Given this list of marker genes PSME2, DENND2C, AGR2, BAALC-AS1, PSMB8, KCNE2, HTN1, FUT1, OPRPN, FLCN, GBP4, MAP3K20-AS1, SECTM1, SFXN2, SERPING1 (NCBI Gene Id 710), CRISPLD2, SLC2A12, TMCO5B, MYRFL, HCAR3, LAMA3, SYPL2 (synaptophysin like 2), WBP2NL, MMP25, UPB1, WARS1, FIZ1, THUMPD2, ANKRD22 (NCBI Gene Id 118932), RNF149, CALHM6, RHOC, APOL1, CREM, SLC25A31, APOL6, APOL4, MAP4K5, AK8, HLA-DRB1, ASZ1, SLC16A1, PLEKHA7, HRH4, INHBA, SPON1, SLC25A35, TXN, NLRC5, GEMIN2, SCLY, ZNF276, CARTPT, NDUFA10 (NCBI Gene Id 4705), STAT1, IGF2BP3, TRIM26, IL17D, TRIM69, CAMK2D, HORMAD1, ASCC3, GART, PARP14, HLA-A, KLLN, CT83, MAGEB2, HNRNPC, OPN5, CAPN12 (calpain 12), HSP90AB1, SAMHD1, ERAP2, GBP5, HLA-DPA1, OR4D1, TRPC5, CNGB3, FMO4, GBP1, RNF10, HLA-DMA, LYNX1, IRF4, MUC19, FSCB, B2M, LIG3 (DNA ligase 3), PLCB4, TRIM21, KLRD1, HOXC9, HLA-DRA, TLNRD1, ZFR2, PSMA3, TRAFD1, FSIP2, PSMB9, HELLS, GGTA1, LINC01278, MORC1, KDM2A, CEP41, TRIB2, CNTNAP5, BDNF-AS, RGS9BP (regulator of G protein signaling 9 binding protein), ENO1, PPP1R9A, MINAR1, PEG3, HLA-DRB6, CD2, TMEM229B, TMEM135, GDI2, SCAPER, PSMA2, MR1, DYNC1H1, STX5, FAM226B, TMEM39A, BTN3A1, PPP4R3A, SCGB1D2, ABT1, TMEM156, LINC01973, MRGPRX1, SPRR2B, OR2M4, IRF1, DCLK1 (doublecortin like kinase 1), DNPEP, HLA-DQB1, GIMAP2, PRPS2, PER3P1, NECTIN3, SIPA1L1, OR8D2, IL36RN, ENSG00000237250, UGT2B4, KIR3DL1, VPS9D1, KRTAP9-9, LINC00887, DNAJA1, HLA-B, RMDN3, NLRC3, GPR174, IL12RB1, SP140L (SP140 nuclear body protein like), ZNF236-DT, UBE2L6, TAP2, ADH1A (alcohol dehydrogenase 1A (class I), alpha polypeptide), POLB, FKBP2, GIMAP8, PDP1, ARHGEF28, CALCOCO2, KIR2DS3, TVP23A, LINC02223, LINC01142, GBP2, SSX1, E2F7, AP3M2, HLA-DPB1, CKAP2, SLC25A20, TOX2, PLAAT4, PLEKHO1, IQCH, STARD8, RAB30, BTN3A2, TTLL7, RMND1, ZNF876P, ZNF536, KCNE1, DSC1, CD74, TNF, GPX2, here is a description of the gene set: species: Homo sapiens Genes down-regulated in CD4 T cells activated by anti-CD3 and anti-CD28: TGFB1 and IL-12 (48h) versus IL4 (48h). Th1 and Th2 cells arise from a common precursor cell in response to triggering through the TCR and cytokine receptors for IL-12 or IL-4. This leads to activation of complex signaling pathways, which are not known in detail. Disturbances in the balance between type 1 and type 2 responses can lead to certain immune-mediated diseases. Thus, it is important to understand how Th1 and Th2 cells are generated. To clarify the mechanisms as to how IL-12 and IL-4 induce Th1 and Th2 differentiation and how TGF-beta can inhibit this process, we have used oligonucleotide arrays to examine the early polarization of Th1 and Th2 cells in the presence and absence of TGF-beta after 0, 2, 6 and 48 hours of polarization. Human Gene Set: GSE2770_IL12_AND_TGFB_VS_IL4_TREATED_ACT_CD4_TCELL_48H_DN from publication Lund R, Aittokallio T, Nevalainen O, Lahesmaa R (PMID 14607935)